The following is a description of a gene set: from publication Chang WL, Coro ES, Rau FC, Xiao Y, Erle DJ, Baumgarth N (PMID 17237394) species: Homo sapiens Influenza virus infection-induced gene expression changes of regional B cells are mediated at least in part through type I Interferon: Our objective is to determine whether the influenza virus-infection induced gene expression changes in regional lymph node B cells are facilitated at least in part through type I interferon. Our specific aim is to compare the gene expression profile of highly FACS-purified B cells in the regional lymph nodes of wildtype and IFNR-/- mice prior to and 48h following infection with influenza virus infection and to contrast this expression profile with that of FACS-purified wildtype B cells activated in vitro with IFN-beta +/- anti-CD86 for 12h. Genes up-regulated in lymph node B lymphocytes: influenza infection versus un-infected. Human Gene Set: GSE3203_HEALTHY_VS_INFLUENZA_INFECTED_LN_BCELL_UP, and this is the list of marker genes: MON2, C12orf42, TSN, MAP2K1, ZNF638, SCD, DDX39A, TUT7, ZNF474, ST3GAL5, KLKB1, SNX29, STPG4, NANS, DMWD, FDPS, SLC25A46, CYTL1, PROK2, HECW2, ITIH1, NADSYN1, GSN, RAB28, ARPC2, MYH6 (NCBI Gene Id 4624), LRRC57, ART5, ASCL1, ERO1B, LCLAT1, WIPF2, LETM1, RBM28, RASA2, EFCAB2, CEP120, CENPB, DENND2D, CD180, SPCS3, NSMCE2, TRPM4, HDAC1, PACSIN1 (NCBI Gene Id 57564), PER2, BOLA3, NSMCE1, CASQ2, KAZALD1, ADAM9, STAT3, WDR81, FANCM, NKIRAS1, ZNF263, TMEM88, BLOC1S6, CYP2A6, CFAP263, CNOT6L, YIF1A, BRWD1, FBXO30 (NCBI Gene Id 84085), SCAF4, CIITA, SYF2, CD276 (CD276 molecule), PIK3CG, USP27X, PPIA, FCER2, HAGH, RBM45, ORAI1, PLEKHJ1, C3orf80, GMPS, LANCL3, BLVRB, PVALB, FSIP1, LMOD3, CPEB1-AS1, MAP3K14, LCP1, CEP126, HOXA13, BAZ2B, TMUB1 (transmembrane and ubiquitin like domain containing 1), TEX9, HSD17B7, MNS1, DDX25, BRPF1, IL4R, SLC18A2, STAG2, PAG1, BRME1, AMZ2, CCDC77, TRMT12, SWAP70, GAB1, PCSK6, GABARAPL2, VPREB3, ERP44, CRELD2, RAB3IP, UNC50, TLCD2, TBCB, MYH2, RHOA, PSKH1, EPHX1, TSPAN13, IFNB1, PAX5, PLD3, MN1, GABRA3, CAST, TFAP2D, CHST3, SLC16A6, WIPI1, LIMD2, F8, RBM10, FCHSD2 (NCBI Gene Id 9873), FIBCD1, SPATA24, APOE, ELF5, CPM, UBA6, PIP5K1A, MARS1, TTL, BRK1, SOHLH2, PRIM2, GALNT1, HOMER3, NPAS2, CDH22, SLC4A7, CD83, PAPPA2, KLF15, RPA1, PRSS23, ARL5A, SCG5, SSC4D, NUP133, SKIDA1, EPRS1, KLF7, BCO1, DNAJC13, PRR13 (proline rich 13), GRPR, RNF151, HLA-DRB1, STARD3NL, PRICKLE3, EML1, SCML2, SLA2, DSCC1 (NCBI Gene Id 79075), DNAI3, USP1 (NCBI Gene Id 7398), TMEM200A, EXOC3L1, PIK3R1, ELP5, MED30, SPAG5, MINDY1, NFATC2, PSMB4, PPP2R5E, ABTB3, RNF145, SFT2D1, OTULIN, SLC6A16, JPT1, GGPS1, CASZ1, LCK, ALDOC, SPMAP2, CCL28, NELFA, ACHE (NCBI Gene Id 43)